Given this list of marker genes IRF8, CTRL, NUDT13, HOXA11, NPHS1, PI4K2A, TCAF2, PIP5K1C, ATG16L1, GPANK1, ARL6IP1, CACNA1D, UBR4, CLN8, PROKR1, PPP1R15A, DDX4, FAU, TFEC, BAZ2A, PIK3CD, ITPRID2, SORL1, DPM2, RUNX3, SENP3, LSR, ATG3, NAV2, RBKS, CSNK1G2, ZNF623, DPEP3, WDSUB1, KLC4, RSPH9, SNAPC2, SCAMP2, CYP27A1, MRPS30, SECISBP2 (SECIS binding protein 2), COX15, PRR14, NAGA, PITPNA, CCNE1, PLEKHA2, CDC37L1 (NCBI Gene Id 55664), MMP19, GCA, ACADL, COX18, DDX5, TRIM32, TP53INP1, COMTD1, DCLRE1A, PLOD3, FGFR2, FUCA2, PLEKHO1, TENM4, SEPTIN8, PTCD1, NAAA, RNF38, RRP36, ASB11, CBX6, RTF2, CEP15, FAM120A, SORCS2, ABCG1, NONO, ATP11B, SNRK, RBCK1 (RANBP2-type and C3HC4-type zinc finger containing 1), TMEM222, LAG3, NDRG1, F5, OXCT1, TCOF1 (treacle ribosome biogenesis factor 1), SYS1, TCF7L2, NUMB, CCNT2, GDA, RIC8A, BMI1, SCIN, RASSF8, RAB8B, CPNE1, DEK (NCBI Gene Id 7913), DDR2, FAM234B, THRAP3, CTSB, THAP12, HACE1 (NCBI Gene Id 57531), STAT4, NAA20, SEC14L2, MTBP, ARHGAP10, CD151, TANGO2, GTF2F1, RRP7A, CAPG, BRWD1, TMA16, POLR1C, RXRB, CBFA2T3, VPS37B, UBC, STX8 (NCBI Gene Id 9482), ARHGEF2, EXT1, GRN, GPATCH1, CSRP1, ATF7IP, APLP2, ALLC, KATNA1, CSK, SH3BP4, GIT1, FBXW11, ARHGAP45, POU3F2, PTS, LIPA, PMM2, CD200R1, HINT3, ZFYVE26, IDS, PAPOLG, TRPC4, KCNK13, ACYP2, CD46, LUC7L3, LRRC8C, INTS12, SESN2, GOT1, SKP2, TECPR1, COL10A1, SEC22A, MCM10, AIF1, JARID2, CCNJ, SLC6A17, ZMIZ2, RELL1, SMIM3, SFSWAP, LY75, HKDC1, PDE6D, CDH20, CFLAR (NCBI Gene Id 8837), KRT33A, COLEC12, YTHDF1, IFT22, ALDH1B1, RBM6, THY1, SMO, TMEM209, MED20, SRP68, LGMN, DEPDC7, PARP12, TMEM192, AK5, KAT2B, RPP21, SFT2D2, FAM3C, SCAND1, DNASE1L1 (NCBI Gene Id 1774), MYO10, NEU1, NCBP2AS2, RMND5B, ARL14EP, ST6GALNAC4, STK24, here is a description of the gene set: mouse primary BMDCs were stimulated with tlr ligands and gene expression changes were profiled on Affymetrix arrays from publication Amit I, Garber M, Chevrier N, Leite AP, Donner Y, Eisenhaure T, Guttman M, Grenier JK, Li W, Zuk O, Schubert LA, Birditt B, Shay T, Goren A, Zhang X, Smith Z, Deering R, McDonald RC, Cabili M, Bernstein BE, Rinn JL, Meissner A, Root DE, Hacohen N, Regev A (PMID 19729616) studied in species Homo sapiens Genes up-regulated in comparison of dendritic cells (DC) stimulated with poly(I:C) (TLR3 agonist) at 24 h versus DC cells stimulated with Pam3Csk4 (TLR1/2 agonist) at 24 h. Human Gene Set: GSE17721_POLYIC_VS_PAM3CSK4_24H_BMDC_UP